The following is a description of a gene set: species: Homo sapiens Human Gene Set: GOMF_SINGLE_STRANDED_DNA_3_5_DNA_EXONUCLEASE_ACTIVITY Catalysis of the sequential cleavage of mononucleotides from a free 3' terminus of a single-stranded DNA molecule., and this is the list of marker genes: EXD2, MEIOB, ISG20, EXO5, POLE, POLG